The following is a description of a gene set: After phosphorylated SMAD2 and/or SMAD3 form a heterotrimer with SMAD4, SMAD2/3:SMAD4 complex translocates to the nucleus. In the nucleus, linker regions of SMAD2 and SMAD3 within SMAD2/3:SMAD4 complex can be phosphorylated by CDK8 associated with cyclin C (CDK8:CCNC) or CDK9 associated with cyclin T (CDK9:CCNT). CDK8/CDK9-mediated phosphorylation of SMAD2/3 enhances transcriptional activity of SMAD2/3:SMAD4 complex, but also primes it for ubiquitination and consequent degradation. <br><br>The transfer of SMAD2/3:SMAD4 complex to the nucleus can be assisted by other proteins, such as WWTR1. In human embryonic cells, WWTR1 (TAZ) binds SMAD2/3:SMAD4 heterotrimer and mediates TGF-beta-dependent nuclear accumulation of SMAD2/3:SMAD4. The complex of WWTR1 and SMAD2/3:SMAD4 binds promoters of SMAD7 and SERPINE1 (PAI-1 i.e. plasminogen activator inhibitor 1) genes and stimulates their transcription. Stimulation of SMAD7 transcription by SMAD2/3:SMAD4 represents a negative feedback loop in TGF-beta receptor signaling. SMAD7 can be downregulated by RNF111 ubiquitin ligase (Arkadia), which binds and ubiquitinates SMAD7, targeting it for degradation. <br><br>SMAD2/3:SMAD4 heterotrimer also binds the complex of RBL1 (p107), E2F4/5 and TFDP1/2 (DP1/2). The resulting complex binds MYC promoter and inhibits MYC transcription. Inhibition of MYC transcription contributes to anti-proliferative effect of TGF-beta. SMAD2/3:SMAD4 heterotrimer also associates with transcription factor SP1. SMAD2/3:SMAD4:SP1 complex stimulates transcription of a CDK inhibitor CDKN2B (p15-INK4B), also contributing to the anti-proliferative effect of TGF-beta. <br><br>MEN1 (menin), a transcription factor tumor suppressor mutated in a familial cancer syndrome multiple endocrine neoplasia type 1, forms a complex with SMAD2/3:SMAD4 heterotrimer, but transcriptional targets of SMAD2/3:SMAD4:MEN1 have not been elucidated. <br><br>JUNB is also an established transcriptional target of SMAD2/3:SMAD4 complex. Reactome Pathway: SMAD2/SMAD3:SMAD4 heterotrimer regulates transcription part of: Transcriptional activity of SMAD2/SMAD3:SMAD4 heterotrimer species: Homo sapiens, and this is the list of marker genes: SMAD2, CDK9, TGIF2, UBB, CCNT1, RBL1, CCNC, SERPINE1, UBC, CDK8, MEN1, TFDP2, MYC, E2F5, CCNT2, JUNB, TFDP1, RNF111, E2F4, SMAD3, TGIF1, EP300, CDKN2B, WWTR1, HDAC1, SMAD7, FURIN, UBA52, YBX1, CCNK, COL1A2, MAPK1, MAPK3, SP1, SMAD4, RPS27A